Given this list of marker genes DHFRP5, KHDRBS2, GAPDHP41, RBBP4P3, PRIM2BP, here is a description of the gene set: Human Gene Set: chr6q11 studied in species Homo sapiens